Given this list of marker genes Cpeb3, Usp9x, Becn2, Zfp608, Fcho2, Cd83, Slc7a12, Nckap1l, Sostdc1, Rapgef4, Spink2, Irag2, Bicd2, 4930571K23Rik, Kcnd2, Cfap418, Chfr, Add3, Prr16, Ube2d3, Ado, Adss1, Tll1, Zfp759, Pcdh7 (NCBI Gene Id 54216), Fhl1, Smu1 (NCBI Gene Id 80521), Mapk8, Pdgfrl, Slc17a5, Cnot2, Nefh, Zfp157, Ndn, Nxph1, Clcn4, Plcl1, Ocstamp, Aak1, Bysl, Ano6, Chd6, Zfp711, Stxbp1, Ankrd28, Rin2, Amd2, Itgae, Gnas, 4833439L19Rik, Ptpre, Lhfpl3, Tmem123, Lrrc19, Ciita, Map2k1, Nhlrc2, Hmgb2, Jtb, Cnih2, Tbc1d23, Prmt3, 1700066M21Rik, Amd1, Ube2w, Jade3, Aff3, Prokr2, Tmem94, Zbtb5, Mthfr, Dcp1a, Degs1l, Shox2, Lef1, Tnks, Rnf152, Vps4b, Dcaf7, Mecp2, Kcnh1, Xiap, Pi4k2b, Fzd3, Dkc1, here is a description of the gene set: from publication Chen Y, Wang X (PMID 31504780) species: Mus musculus Genes predicted to be targets of miRBase v22 microRNA mmu_miR_1912_5p in miRDB v6.0 with MirTarget v4 prediction scores > 80 (high confidence targets). Mouse Gene Set: MIR_1912_5P